The following is a description of a gene set: studied in species Homo sapiens Human Gene Set: GOBP_PROTEIN_RETENTION_IN_GOLGI_APPARATUS The retention of proteins within the Golgi apparatus. Golgi-localized carbohydrate-modifying enzymes have a short N-terminal domain that faces the cytosol, a single transmembrane alpha helix, and a large C-terminal domain that faces the Golgi lumen and that contains the catalytic site. How the membrane-spanning alpha helix in a Golgi enzyme causes its localization and prevents its movement to the plasma membrane is not known., and this is the list of marker genes: SORL1, VPS13A, VPS13D, VPS13C (vacuolar protein sorting 13 homolog C), GOLPH3